Given this list of marker genes Apobec1 (apolipoprotein B mRNA editing enzyme, catalytic polypeptide 1), Adarb1 (adenosine deaminase, RNA-specific, B1), Apobec4, Adar, Apobec2, Apobec3, A1cf, here is a description of the gene set: mRNA Editing studied in species Mus musculus Mouse Gene Set: REACTOME_MRNA_EDITING